The following is a description of a gene set: Genes expressed from the Y chromosome, so that higher levels indicate greater male identity (numbers) in pooled specimens. Mouse Gene Set: HEVNER_Y_CHROMOSOME_EXPRESSION studied in species Mus musculus from publication Bedogni F, Hevner RF (PMID 34321999), and this is the list of marker genes: Kdm5d, Uty, Eif2s3y, Uba1y, Ddx3y